The following is a description of a gene set: Human Gene Set: GOBP_MEMBRANE_BIOGENESIS A cellular process that results in the biosynthesis of constituent macromolecules, assembly, and arrangement of constituent parts of a membrane. species: Homo sapiens, and this is the list of marker genes: CHMP4A, VPS4A, REEP4, PTPRD, BROX, ANK3, NLGN4X, SPAST, NLGN1 (neuroligin 1), EPHB2, IQGAP1, STX4, NSFL1C, PTEN, SELENON, CAV1, CLIP3, NLGN2, EMP2, UBXN2A, CAV2, ANKLE2, CHMP4C, CHMP2B, TLCD2, CHMP4B, ILK, NRXN2, UGCG, MIR138-1, BANF1, CHMP4BP1, CHMP3, CHMP5, CHMP1B, CHMP2A, PEX19, STX2, SPTBN1, CHMP7, NLGN3, TLCD1, UBXN2B (UBX domain protein 2B), UBE2I (NCBI Gene Id 7329), CHMP6 (charged multivesicular body protein 6), PACSIN2, PEX11A, NRXN1, CDH2, RCC1, RFTN1, LRCH4, ANXA2, JOSD1, DMKN, FLOT1, MAFB, S100A10, IL1RAPL1, COL6A1, LRP4, PEX16 (peroxisomal biogenesis factor 16), SIRT2, CAV3, REEP3, SERINC1, HDAC3, CHMP1A, ZNF750, VPS4B